Given this list of marker genes AHNAK, FKBP9, MIR9-1HG (MIR9-1 host gene), ANLN, NRAS, RHPN2, GSTM4, UACA, PBX4 (NCBI Gene Id 80714), GRHL2, RUNX1, MT1X, KIF3B (kinesin family member 3B), CNTRL, SIMC1P1, VANGL1, OAT, ALG14, PHTF1, CMTM6, here is a description of the gene set: Human Gene Set: KIM_MYCL1_AMPLIFICATION_TARGETS_DN from publication Kim YH, Girard L, Giacomini CP, Wang P, Hernandez-Boussard T, Tibshirani R, Minna JD, Pollack JR (PMID 16116477) Genes negatively correlated with amplifications of MYCL1 in SCLC (small cell lung cancer) cell lines. DNA amplifications and deletions frequently contribute to the development and progression of lung cancer. To identify such novel alterations in small cell lung cancer (SCLC), we performed comparative genomic hybridization on a set of 24 SCLC cell lines, using cDNA microarrays representing approximately 22,000 human genes (providing an average mapping resolution of <70 kb). We identified localized DNA amplifications corresponding to oncogenes known to be amplified in SCLC, including MYC (8q24), MYCN (2p24) and MYCL1 (1p34). Additional highly localized DNA amplifications suggested candidate oncogenes not previously identified as amplified in SCLC, including the antiapoptotic genes TNFRSF4 (1p36), DAD1 (14q11), BCL2L1 (20q11) and BCL2L2 (14q11). Likewise, newly discovered PCR-validated homozygous deletions suggested candidate tumor-suppressor genes, including the proapoptotic genes MAPK10 (4q21) and TNFRSF6 (10q23). To characterize the effect of DNA amplification on gene expression patterns, we performed expression profiling using the same microarray platform. Among our findings, we identified sets of genes whose expression correlated with MYC, MYCN or MYCL1 amplification, with surprisingly little overlap among gene sets. While both MYC and MYCN amplification were associated with increased and decreased expression of known MYC upregulated and downregulated targets, respectively, MYCL1 amplification was associated only with the latter. Our findings support a role of altered apoptotic balance in the pathogenesis of SCLC, and suggest that MYC family genes might affect oncogenesis through distinct sets of targets, in particular implicating the importance of transcriptional repression. studied in species Homo sapiens